The following is a description of a gene set: species: Homo sapiens A form of colorblindness in which only two of the three fundamental colors can be distinguished due to a lack of one of the retinal cone pigments. Human Gene Set: HP_DYSCHROMATOPSIA Dyschromatopsia, and this is the list of marker genes: RBP4, CEP78, PDE6H, IMPG1, OPN1MW, BEST1, SAG, FOXC1, TK2, CNGB3, CNGA3, PAX6 (paired box 6), ADAM9, RPGR, RAX2, RPGRIP1, ACO2, C1QTNF5, FGF14, TTLL5, DNM1L, PDE6C, UNC119, TMEM126A, MFSD8 (major facilitator superfamily domain containing 8, NCBI Gene Id 256471), TRIM44, OPA1, GUCY2D, GUCA1A, MTRFR, NMNAT1, RIMS1, TLCD3B, CACNA1F, AFG3L2, PITPNM3, OPN1LW, SEMA4A, ABCA4, ATF6, NR2E3, POC1B, RAB28, MORC2, OPA3, CDHR1, AIPL1, CACNA2D4, MCAT, CFAP410, PROM1, CFAP418, CRX, OPN1SW, DRAM2, GRK1, POLG (DNA polymerase gamma, catalytic subunit), PRPH2, NDUFS2, MECR